The following is a description of a gene set: Marker genes curated from the annotated cluster as represented in the Descartes Human Gene Expression During Development database. Human Gene Set: DESCARTES_FETAL_PLACENTA_MYELOID_CELLS The gene expression program underlying the specification of human cell types is of fundamental interest. The study authors generated human cell atlases of gene expression and chromatin accessibility in fetal tissues. For gene expression, the study authors applied three-level combinatorial indexing to >110 samples representing 15 organs, ultimately profiling ~4 million single cells. The study authors leveraged the literature and other atlases to identify and annotate hundreds of cell types and subtypes, both within and across tissues. Our analyses focused on organ-specific specializations of broadly distributed cell types (such as blood, endothelial, and epithelial), sites of fetal erythropoiesis (which notably included the adrenal gland), and integration with mouse developmental atlases (such as conserved specification of blood cells). These data represent a rich resource for the exploration of in vivo human gene expression in diverse tissues and cell types. from publication Cao J, O'Day DR, Pliner HA, Kingsley PD, Deng M, Daza RM, Zager MA, Aldinger KA, Blecher-Gonen R, Zhang F, Spielmann M, Palis J, Doherty D, Steemers FJ, Glass IA, Trapnell C, Shendure J (PMID 33184181) species: Homo sapiens, and this is the list of marker genes: CYP2S1, SLC38A6, ACP5, FOLR2, IGSF6, HK3, SPP1, C1QA, CD163L1, CHI3L1, CYBB, MAFB, CIITA, ENSG00000227531, HS3ST2, IL4I1, BCL2A1, TLR6, HPGDS, NRIR, ENSG00000253557, LST1, CD28, VSIG4, HLA-DQB1, KCNE1 (NCBI Gene Id 3753), RAB39A (NCBI Gene Id 54734), RUBCNL, LTA4H, C3AR1, RYR1, LAIR1, LGALS2, CLEC7A, CD14, TYROBP, HLA-DMA, FAM20C, CD86, LINC01094, LY86, HLA-DRA, MRPL2, SLC11A1, FCGR1A, C5AR1, NLRP3, SLAMF8, CCL2, SLC37A2, CD74, CD83, SDS, SCIMP, CXCL10, CXCL16, MMP9, ADAMDEC1, CLEC9A, TLR2, BFSP2, CPVL, STAB1, PLA2G2D, HLA-DRB5, MNDA, IGSF21, HLA-DRB6, HLA-DQA1, PADI2, ADGRE2, OSCAR, LRRC39, LACC1 (laccase domain containing 1), FCGR3A, MPEG1, HCK, THEMIS2, MILR1, TNFAIP8L2, CALHM6, CD5L, C1QB, ICAM1, LYZ, ANKRD22, RNASE6, FPR3, LILRA6, ARL11, SIGLEC10, RASSF4, TFEC, LRRC25 (NCBI Gene Id 126364), MARCO, NFAM1, PRAM1, LGMN, MARCHF1, SUCNR1, KCNAB1, LILRB4, FGD2, HLA-DPA1, P2RX7, ADAP2, CCL13, SIRPB2, CXCL11, ZEB2-AS1, LILRB2, TLDC2 (NCBI Gene Id 343574), S100A8 (NCBI Gene Id 6279), ARHGAP22, LINC02698, EREG, TOR4A, HLA-DOA, SIGLEC1, TLR7, CD163, TMEM273, C1QC, HLA-DRB1, FGL2, LAMP3, GNA15, KCNJ5, MS4A7, CXCL9, SLC7A7, HLA-DPB1, CTSZ, MS4A6A, ST18, LINC03070, GPR141, PPM1M, GGTA1, LINC02798, LINC00970, CHIT1 (NCBI Gene Id 7831), PLTP, C1orf162, TPRG1 (NCBI Gene Id 285386), RBPJ, EGR2, SIGLEC9